Given this list of marker genes BMP1, GRIP1, FRAS1, FREM2, DYM, HNRNPR, RUNX2, here is a description of the gene set: Wide pubic symphysis Abnormally increased width of the pubic symphysis is the midline cartilaginous joint uniting the superior rami of the left and right pubic bones. Human Gene Set: HP_WIDE_PUBIC_SYMPHYSIS species: Homo sapiens